The following is a description of a gene set: from publication Cui A, Huang T, Li S, Ma A, Pérez JL, Sander C, Keskin DB, Wu CJ, Fraenkel E, Hacohen N (PMID 38057668) species: Mus musculus Genes positively differentially expressed in cell type: Monocyte upon treatment with cytokine: IL-1β in mouse lymph nodes in vivo. Cytokines mediate cell-cell communication in the immune system and represent important therapeutic targets. A myriad of studies have highlighted their central role in immune function, yet we lack a global view of the cellular responses of each immune cell type to each cytokine. To address this gap, the authors created the Immune Dictionary, a compendium of single-cell transcriptomic profiles of more than 17 immune cell types in response to each of 86 cytokines (>1,400 cytokine-cell type combinations) in mouse lymph nodes in vivo. A cytokine-centric view of the dictionary revealed that most cytokines induce highly cell-type-specific responses. For example, the inflammatory cytokine interleukin-1β induces distinct gene programmes in almost every cell type. A cell-type-centric view of the dictionary identified more than 66 cytokine-driven cellular polarization states across immune cell types, including previously uncharacterized states such as an interleukin-18-induced polyfunctional natural killer cell state. Mouse Gene Set: CUI_MONOCYTE_IL1B_RESPONSE_UP, and this is the list of marker genes: P4hb, Thbs1, Chil3, Hdlbp, Havcr2, Atp5mc1, Srp9, Irf2bp2, Ran, Hnrnph2, Txn1, Krtcap2, Jaml, Msr1 (NCBI Gene Id 20288), Pilra, Jmjd1c, Nme1 (NME/NM23 nucleoside diphosphate kinase 1), Mdh2, Hsd17b12, Ehd1, Pebp1, Arhgap26, Srgn, Bak1, Rnh1, Litaf, Sh3bgrl, Ifitm2, Rhoh, Tiam1, Bcl2a1a, Rab5c (RAB5C, member RAS oncogene family), Hnrnpa2b1, Slc15a3, Ccl12, S100a10, Saa3, Ms4a6d, Manf, Adprh, Tarm1, Plek, Ybx1, Tmed9, Sla, Dab2, Eps8, Adam8, Ltb4r1, Lrrfip1, Rab44, Xbp1, Tpm3, Fth1 (NCBI Gene Id 14319), Picalm, Slc2a1, Cox17, Ftl1, Ccl2, Tmed2, Itgam, Rgl1, Eif3a, Dmkn, Ddit4, Olfm1 (NCBI Gene Id 99427), Slc39a14, Slc39a7, Tfec, Rbpj, Mydgf, Man2a1, Pfn1, Hs3st3b1, Mt1, Mrpl52, C5ar1, Gda, Tcf7l2, Cndp2, Eif2s1, Runx1, Ap2a2, Gapdh, C3ar1, Srsf2, Zfp292, Nsd2, Tpm4, Sod2, Il1r2, Ranbp1, Fkbp5, Cdh1, Cstb, Il1rn (interleukin 1 receptor antagonist), Pdia6, Rab3il1, Id2, Uck2, Srm, Clec4d, Calr, Dok2, Pkm, Cfp, Slfn1, Tgm2, Ebna1bp2, Rbbp6, Mgat2, Hnrnpm, Atp11a, Ap3s1, Ctsd, Vim, Vapa, Rab20, Rbm3, Lcn2, Bcl2a1b, Spcs2, Rhou, St7, Fcgr3, Ppp1r14b, Sh3pxd2b, Atp1a1, Sfxn1 (NCBI Gene Id 70119), Basp1, Tes, Ralb, Ldha, Rbms1, Plaur, Clec4n, Eif4a1, Lgmn, Cfl1, Il4ra, Slc11a1, Nsun2, App, Cish, Gsr, Cers2, Cltc, St6galnac4, Enah, Ostc, Txnrd1, Eif5a, Bcl2a1d, Fcgr2b, Ccl24, Ccr5, Cd300lf, Arrdc4, Morf4l2, Socs3, Hspa5, Ptpn1, Anxa2, Lrrc59, Nolc1, Eif1, Fcer1g, Vcan (versican), Heatr1, Hnrnpab, Igfbp6 (insulin-like growth factor binding protein 6), Slc3a2, Ninj1 (ninjurin 1), Ffar2, Reep3, Ifi207, Spred1, Wnk1, Cd164, Bnip2, Ccr1, Snx3, N4bp1, Tmem65, Cd53, Ctsl, Ier3, Glrx (glutaredoxin), Ifitm1, Cd44, Eef1g, Fabp5, G3bp1, Snx2, Mrc1, Cd244a, Bax, Tgfbi, Snx5, Slfn2, Mafb, Sec11a, Hif1a, Card19, Tbcb, Sdc4, Scimp, F10 (NCBI Gene Id 14058), Cmklr1, Nab2, Sys1, Lilrb4b, Bst1, Cd33, Atp5f1b, Hnrnpa3, Casp6